The following is a description of a gene set: A protein complex that is part of a mitochondrion. species: Homo sapiens Human Gene Set: GOCC_MITOCHONDRIAL_PROTEIN_CONTAINING_COMPLEX, and this is the list of marker genes: CLPX (NCBI Gene Id 10845), MRPL44, MRPS14, MRPS21, PHB2, MRPL20 (NCBI Gene Id 64994), GADD45GIP1, PAM16, GRPEL2, TIMM17A, ISCU, TOMM40 (translocase of outer mitochondrial membrane 40), SAMM50, TOMM7, MRPS22, APOO, MRPL21, TRMT10C, MRPL47, MRPL12, MICOS10, MRPS26, IMMP1L, MRPL38, TOMM5, PNPT1, PHB1, TIMM13, MRPS25, MRPS33, MCUB, TIMM22, MRPS18B, BAX, NSUN4, CHCHD6, TOMM20L, MICU3, MRPS10, MTX1, MRPL37, MRPS30, SLC25A6, MPC2, CHCHD1, IMMP2L, TIMM8B, MRPL24, SPG7, MRPS34, TIMM23, MRPL9, PDSS2, TIMM17B, MRPL17, TIMM44, FXN, MCU, MRPL15, MRPL34, MRPS11, MRPL41, MRPL53, MRPL4, TIMM10B, NSUN3, TIMM50, MRPL36, HSD17B10, MRPS9, VDAC1, POLRMT, MRPL3 (mitochondrial ribosomal protein L3), MRPL58, MRPS7, AFG3L2, MRPL57, TOMM20, TIMM23B, POLG (NCBI Gene Id 5428), MRPL27, MRPL1, MTERF4, MFN1, MRPL54, AGK, TOMM40L, PRORP, MRPL46, ACACB, MRPL42, MRPL2, MRPS12, MRPL45, MRPS2, TOMM22, MRPL39, MRPL43, MRPS35, MRPS5, MRPL35, TIMM8A, TOMM70, MRPL22, PPIF, MRPS28, MRPL28, HADHA, MRPS31, MRPL48, PMPCA, MICU2, MRPL40, MTX2, ISCA1, NFS1, SLC25A5, MPC1, HSPA9, AURKAIP1, MRPL23, MRPL14, MRPS27, ISCA2, MRPL55, MRPL52, PDSS1, MICU1, MRPS16, GRPEL1, DAP3, TRMT10B, SUPV3L1, MRPS6, PTCD3, MRPL32, POLG2 (DNA polymerase gamma 2, accessory subunit), DNAJC11, MRPL33, TIMM9, MRPL10, DNA2 (DNA replication helicase/nuclease 2), MRPL13, DNAJC15, NDUFAB1, MRPL30, TIMM10, TOMM6, CHCHD3, MRPS23, MRPS24, MRPL19, PMPCB, ROMO1, MRPS18A, APOOL, MRPL16, IMMT, MRPS15, CHCHD10, MRPL49, MRPL11, SLC25A31, SLC25A4, MRPL18, DNAJC19, HADHB, MRPS18C, SMDT1 (NCBI Gene Id 91689), TIMM29, MRPS17, MICOS13, TIMM21, MRPL51, MRPL50, MTX3, LYRM4